Given this list of marker genes RBMS1, MATCAP2, GPR161, TMEM167B (NCBI Gene Id 56900), MTA2, here is a description of the gene set: species: Homo sapiens Human Gene Set: MIR4442 Genes predicted to be targets of miRBase v22 microRNA hsa-miR-4442 in miRDB v6.0 with MirTarget v4 prediction scores > 80 (high confidence targets). from publication Chen Y, Wang X (PMID 31504780)